Given this list of marker genes E2F5 (NCBI Gene Id 1875), TFDP1, MEN1, CDK8, RBL1, HDAC1, UBA52, CCNT2, RNF111, SERPINE1, YBX1, CCNK, UBC, MYC, CDK9, TFDP2, TGIF1, MAPK3, CCNC, UBB, E2F4, JUNB, EP300, COL1A2, SMAD4, FURIN, CCNT1, SMAD7, SP1, RPS27A, WWTR1, TGIF2, SMAD2, SMAD3, MAPK1, CDKN2B, here is a description of the gene set: Human Gene Set: REACTOME_SMAD2_SMAD3_SMAD4_HETEROTRIMER_REGULATES_TRANSCRIPTION SMAD2/SMAD3:SMAD4 heterotrimer regulates transcription studied in species Homo sapiens